Given this list of marker genes Rnf216, Daam1, Skida1, Spart, Relch, Ulk2, Rab5a, Tsc1, Cfl2, Il25, Kmt2c, Psd, Impdh1, Tbl1xr1, Chst1, Ptp4a1, Tes, Zbtb18, Snx2, Thsd7a, Eda, Esr1, Mllt6, Stx6, Sphk2, Arhgap21, Cnot7, G3bp2, Plcb1, Zfp655, Naa30, Eogt, Btf3l4, Dsel, Tnf, Lrrtm2, Calm2, Cbfb, Socs6, Pdgfra, Laptm4a, Clip1, Larp4, Klhl20, Pak6, Sh3d19, Akap11, Mapk8, Lgalsl, Caprin2, Gga3, Mat2b, Nsd3, Fut9, Med15, Pmepa1, Itpr1, St6galnac3, Csnk1g1, Cdk19, Ankib1, Ston2, Mbnl1, Lrp8, Dpysl2, Bnip2, Cep170, Pou4f1, Jade1, Btaf1 (NCBI Gene Id 208902), Btbd3, Tnrc6c, Mid1ip1, E2f2, Stxbp5 (NCBI Gene Id 78808), Neurog1, Zmat3, Map3k12, Snapin, Hprt1, Snx5, Rfx7, Cnot6, Kdm2a, Jarid2, R3hdm1, Phf12, Tbcel, Wnk1, Pxk, Fmr1, Dennd10, Rasd1, Lrp4, Pik3cb, Dgke, Usp32, Cmpk1, Hoxb1, Kcnj2, St8sia5, Prkd3, Zbtb4, Blcap, Mctp1, Zfp11, Ago4, Zfp609, Ereg, Gpr137c, Abcc5, Smoc2, Sel1l3, Stimate, Gja1, Elk3, Fcho2 (NCBI Gene Id 218503), Prr14l, Acsl1, Mdfic (MyoD family inhibitor domain containing), Wee1, Jmy, Stim2, Ago1, Sowahb, Ptprg, Nectin3, Sulf1, Casd1, Ddx6, Atp2b2, Acsl4, Erbin, Wnt2b, Arap2, Prkaa1, Lonrf3, Adcy1, Tshz1, Smoc1, Spred1, Usp8, Akirin2, Dnajc24, Rtn1, Sgcb, Atxn1, Spire1, Fastk, Btg1, Maf, Tgfbr1, Appl1, Phf3, Heg1, Adamts20, Gng12 (guanine nucleotide binding protein (G protein), gamma 12), Dcbld2, Zcchc14, Nacc2, Miga2, Mecp2, Smarcd2, Zfp113, Phaf1, Dll1, Acer2, Ldaf1, St18, Ppp6r1 (protein phosphatase 6, regulatory subunit 1), Sybu, Med12l, Mon2, Arhgap1, Lonrf1, Abhd3, Tbc1d12, Kcna4, Mphosph9, Tmem250, Rnf38, Mmgt1, Ubl3, Mybl1, Wdfy3, Snip1, Mex3d, Mdn1, Socs5, Nol4, Memo1, Cd69, Pparg, Arhgap12, Togaram1, Gon4l, Hs3st5, Ldlrad4, Map3k8, Emx2, Dennd1a, Fibin, Ar, Acbd5, Vps29, Mb21d2, Robo2, Atg16l1 (NCBI Gene Id 98282), Cyld (CYLD lysine 63 deubiquitinase), Csmd1, Garem1, Ube2d2a, Pcnx1, Epc2, Rap2c, Acvr1, Psap, Mdm4, Nckap5, Clcn5, Tapt1, Brwd1, Enpp5, Mapk1, Smad5 (NCBI Gene Id 76327), Plekhg5, Reps2, Vps37a, Gpatch8, Cltc, Pgm2l1, Cds1, Iqgap2, Tbc1d8, Tspyl2, Tet3, Psd3, Mfsd6, Btbd7, Fam234a, Slmap, Lrig1, Lcorl, Ccdc126, Fermt2, Sbno1, Npepl1, Cpeb1, Cast (calpastatin), Kbtbd8, Ccny, here is a description of the gene set: studied in species Mus musculus from publication Chen Y, Wang X (PMID 31504780) Genes predicted to be targets of miRBase v22 microRNA mmu_miR_6389 in miRDB v6.0 with MirTarget v4 prediction scores > 80 (high confidence targets). Mouse Gene Set: MIR_6389